The following is a description of a gene set: Any deviation from the normal circulation of leucine in the blood circulation. Abnormal circulating leucine concentration studied in species Homo sapiens Human Gene Set: HP_ABNORMAL_CIRCULATING_LEUCINE_CONCENTRATION, and this is the list of marker genes: MCCC1, MCCC2, BCAT2, PPM1K, BCKDK, ATP5F1B, BCKDHB